The following is a description of a gene set: electronically inferred by orthology from the curated human pathway studied in species Mus musculus part of: Signal Transduction Reactome Pathway: Signaling by WNT This event has been computationally inferred from an event that has been demonstrated in another species.<p>The inference is based on the homology mapping from PANTHER. Briefly, reactions for which all involved PhysicalEntities (in input, output and catalyst) have a mapped orthologue/paralogue (for complexes at least 75% of components must have a mapping) are inferred to the other species., and this is the list of marker genes: Dkk2, Wnt11, Psmc6, Psmc2, Rnf43, Dvl1, Ash2l, Ap2a1, Ppp2r1b, Rspo1, Fzd8, Pygo2, Lrp5, Nlk, Vps26a, Amer1, Wnt16, Pde6g (phosphodiesterase 6G, cGMP-specific, rod, gamma), Kremen1, Rspo3, Psmb5, Csnk1a1, Kremen2, Axin2, Sox2, Leo1, Kmt2b, Fzd4, Chd8, Psma3, Pygo1, Psma6, Psmd13, Sox4, Fzd2, Tnks2, Tcf7l1, Gng5, Cul1, Wnt7a, Psma2, Ctnnb1, Wnt2b, Psmb7, Psmd6, Wnt3, Psmc3, Arrb2, Dkk1 (NCBI Gene Id 13380), Dvl3, Ppp2r5b, Psmd1 (proteasome (prosome, macropain) 26S subunit, non-ATPase, 1), Wnt10a, Smurf2, Klhl12, Frat2, Psmc5, Psmb4, Ryk, Tert, Fzd1, Lgr5, Psmc1, Gngt1, Csnk2b, Ap2m1, Ppp2r5a (NCBI Gene Id 226849), Snx3, Pfn1, Wnt4, Csnk1e, Psma1 (NCBI Gene Id 26440), Bcl9l, Gng3, Sost, Igfals, Rac3, Sox6, Gng11, Ubb, Men1, Prkcg, Smarca4, Tcf7, Fzd6, Gnao1, Wnt8a, Ppp2r5d, Cav1, Vps35, Ap2b1, Prkca, Sox17, Gng7, Ap2s1, Gnb3, Dkk4, Psmd12, Cltb, Gnb2, Sox7, Wnt8b, Xpo1, Frat1 (frequently rearranged in advanced T cell lymphomas), Ppp3r1, Rnf146, Wnt9b, Calm1, Gng4, Psmb6, Wnt10b, Wnt7b, Dvl2, Fzd7, Pde6b, Hecw1, Gnb5, Psma7, Ep300, Wnt1, Rps27a, Wnt5b, Psmd7, Bcl9, Wnt9a, Psma4, Rac2, Axin1, Tcf7l2, Gng8, Gngt2, Psmc4, Smurf1, Wnt3a, Psma5, Znrf3, Sry, Cby1, Plcb3, Gng10